The following is a description of a gene set: studied in species Mus musculus Mouse Gene Set: GOCC_XY_BODY A structure found in a male mammalian spermatocyte containing an unpaired X chromosome that has become densely heterochromatic, silenced and localized at the nuclear periphery., and this is the list of marker genes: Smarcb1, Birc2 (baculoviral IAP repeat-containing 2), Slx, Atr, Smarcc1, Ube2b, Mael, Dmrtc2 (doublesex and mab-3 related transcription factor like family C2), Esco2, Hsf5 (NCBI Gene Id 327992), Scml2, 1700013H16Rik, Spdya, Rad18, Plk4, Dnmt3a, Pbx4, Daxx, Ube2a, Usp7, Sumo1, H2ax, Zcwpw1, Brca1, Sin3b